The following is a description of a gene set: Reactome Pathway: Signaling by FGFR3 electronically inferred by orthology from the curated human pathway studied in species Mus musculus part of: Signaling by FGFR This event has been computationally inferred from an event that has been demonstrated in another species.<p>The inference is based on the homology mapping from PANTHER. Briefly, reactions for which all involved PhysicalEntities (in input, output and catalyst) have a mapped orthologue/paralogue (for complexes at least 75% of components must have a mapping) are inferred to the other species., and this is the list of marker genes: Fgf1, Fgf8, Frs2, Fgf23, Grb2, Shc1, Hras, Fgf17, Spry2, Fgf2, Fgf16, Gab1, Mapk3, Fgf5, Ubb, Fgf4, Rps27a, Cbl, Fgf20